The following is a description of a gene set: studied in species Homo sapiens The chemical reactions and pathways resulting in the formation of a medium-chain fatty acid. A medium-chain fatty acid has an aliphatic tail containing 6 to 12 carbons. Human Gene Set: GOBP_MEDIUM_CHAIN_FATTY_ACID_BIOSYNTHETIC_PROCESS, and this is the list of marker genes: OXSM, OLAH, ACOT7, ABHD1, ABHD3, ABHD2